The following is a description of a gene set: Mouse Gene Set: GOBP_GERMINAL_CENTER_FORMATION species: Mus musculus The process in which germinal centers form. A germinal center is a specialized microenvironment formed when activated B cells enter lymphoid follicles. Germinal centers are the foci for B cell proliferation and somatic hypermutation., and this is the list of marker genes: Unc13d, Tnfrsf13c, Tnfaip3 (NCBI Gene Id 21929), Bcl6, Bcl3, Foxj1, Ada, Pkn1, Klhl6, Nfkb2, Rc3h1, H2-DMa, Tnfsf13b, Tnfsf13, Adam17, Mef2c